The following is a description of a gene set: Human Gene Set: MODULE_562 MMPs. studied in species Homo sapiens, and this is the list of marker genes: ADAM12, TIMP2, MMP1, MMP7, TNF, MMP12, TIMP1, MMP13, MMP3, MMP9, MMP11, ADAM10, CHIT1, MMP10, MMP2, BMP1, MMP15, ADAM9, MMP14, TIMP3, PEPD